The following is a description of a gene set: The aim of this dataset was to study in detail the transcription kinetics initiated by cytokine IL-4 in early differentiation of Th2 cells. from publication Elo LL, Järvenpää H, Tuomela S, Raghav S, Ahlfors H, Laurila K, Gupta B, Lund RJ, Tahvanainen J, Hawkins RD, Oresic M, Lähdesmäki H, Rasool O, Rao KV, Aittokallio T, Lahesmaa R (PMID 20620947) Human Gene Set: GSE17974_IL4_AND_ANTI_IL12_VS_UNTREATED_0.5H_ACT_CD4_TCELL_UP studied in species Homo sapiens Genes up-regulated in comparison of CD4 T cells treated with IL4 and anti-IL12 at 0.5 h versus the untreated cells at 0.5 h., and this is the list of marker genes: GPR183, SLC25A6, VTI1B, CASP4, PCDHGA1, IL12RB1 (interleukin 12 receptor subunit beta 1), TARBP2, LINC00309, LINC02483, ZNF101, TCAF1, DDT, SH2D6, EEF1D, PRDM4, SERPING1, RUNX3, TLX2, CDC42EP5, PSMC1, DENND1A, BRF2, RPL6, ATG9A, POLK, LINC03007, MDK, SYNDIG1L, PNMA3, EQTN, SIRPD, PDZRN4, MCL1, IFITM1, PFDN5, DAP, CCNYL2, LSM10 (LSM10, U7 small nuclear RNA associated), RPL13P5, CPT2 (carnitine palmitoyltransferase 2), TIGD2, RPL10L, FBXO40, PCIF1, ZNF768, SATB2-AS1, PSMG3, RPS17P5, ZNF329, SAA3P, SH3RF3-AS1, CMA1, MED27, OR10H3, LINC01123, HIRIP3, TDRKH, ATP5MJ, NDUFB11, SMAD1, NCR2, TCTA, PPIAL4A, CYP51A1, NME6 (NCBI Gene Id 10201), LACTB2, NUDT18, PTGR2, RBM42, POLR3C, STK16, LGSN, OGN, GPX7, SCRG1, BTG1, LSM12, APOA2, EIF1, CELA3B, LRRC8E, PPCDC, FBXO31, RAD51C, MAF1, DNAJC14, ZNF846 (zinc finger protein 846), CHP1, EIF2S1, ALYREF, CHMP3, YARS1, RTCB, TEX47, EPS8, RBM15B, SUV39H1, KRTAP1-3, NTMT1, KCTD20, EIF3G, EIF3L, GVQW3, AP5S1, B2M, TAGLN3, RPS7, NCF1C, PSMA7, NR1H3, ABCC2, LACTB2-AS1, ASS1, CATSPER3, APOL5, NLRP6, SMPX, CPS1-IT1, GALE, SNX6, MARVELD3, UBE2Q1, LMBR1, UBOX5, HECW1-IT1, DECR2, TRMT12, SNX25, CYB5R3, COX5B, BAIAP2, FLAD1, RPL36, CD69, LINC02532, IL17RE, DTHD1, RPS10P5, CCL28, DNM3, LMNB1, RAD52, H2BC8, CCR6 (C-C motif chemokine receptor 6), NFE4, EEF2, HNRNPA3P1, ZCCHC13, MOCS2-DT, TNFAIP3, METTL13, ACTG1 (NCBI Gene Id 71), H4C4, RGS5, CLDN18, CDK4, GPANK1, PROK2, AKIRIN1, CHRAC1, ZNF684, MIF4GD, MED30, EIF3F, LINC01521, GDE1, PABIR1, OTOS, CAST (NCBI Gene Id 831), GTF2H4, ZCCHC4, DAZAP2, DSCAML1, HCG11, IGFBP1, LRRN2, RPL36AL, FHIT, ERC2 (NCBI Gene Id 26059), NR1I3, UBE2J1, KRBOX1, EHMT2, ZNF777, GTDC1, RPL5, ID2, GET3, EVI2B, ALG1, RPL23AP7